Given this list of marker genes CACNA1D, TPRA1, TIA1, MT-TR, HSD17B14, MTCO3P12, HLA-L, HFE, CFAP418, NCOA7, MT-ND3, SIGLEC11, POLR3E, GNG2 (NCBI Gene Id 54331), AHCY, RAB11A, ATP6V1E1 (NCBI Gene Id 529), GADD45B, CD40, UBE4A, ILF2, GAPDHP76, NPEPL1, LINC02739, ADAT3, POLG-DT, ITPR2, STMN1P1, C16orf54, MT-ND4, GSTA4, LTA4H, PIGN (phosphatidylinositol glycan anchor biosynthesis class N), CNN2, RELCH, MYO18B, HMGA1, SCAMP4, LIMD1-AS1, SOX5, DPP9, PRMT1, AMN1, MT-ND4L, PTK2B, ERVK13-1, LINC02902, PRKXP1, PTGES3, PCOTH, TAPT1, P2RY6, CLEC10A, PRMT5, C2orf42, ENSG00000228044, BTBD10, MIR5194, TRIM28, CRTAP, FKBP1A, MIA3, RAC1, SLC29A3, ATP6V1B2, HCG14, TRMT1, HSPA6, HCK, MT-TG, STX11, ALOXE3, OR10AA1P, DTNB-AS1, NR6A1, EPS8L1, PRMT5-DT (PRMT5 divergent transcript), SACM1L, PGK1, KNOP1P1, FCHO1, LINC02566, KNL1, POLG, here is a description of the gene set: Genes containing one or more binding sites for (CDH4) in their promoter regions (TSS -1000,+100 bp) as identified by GTRD version 20.06 ChIP-seq harmonization. Human Gene Set: CDH4_TARGET_GENES studied in species Homo sapiens from publication Yevshin I, Sharipov R, Kolmykov S, Kondrakhin Y, Kolpakov F (PMID 30445619)